Given this list of marker genes C6orf120, MAPK14, ECE2, CIT, UBE2W, RGS6, UBE2F, PAPPA, FAM133B, CAPN3, PDHX (pyruvate dehydrogenase complex component X), B4GALT3, RNFT1, HNRNPF, RXRA, NETO1, ARFGEF1, PGAP1, CCNJ, NCOA1, PKIA, DPY19L3, FOXP2, HLX, PARD6B, AFAP1, USP42, TMTC2, PEDS1-UBE2V1, HIP1, EIF6, USP46, MKNK2, AKIRIN1, AQP11, ADAM19, ATXN10, CD28, N4BP1, MMD, MBNL2 (muscleblind like splicing regulator 2), HAPLN1 (NCBI Gene Id 1404), CREB1, EPB41L1, WSB1, DNAJC13, FAM13A, MEIS2, SLC39A13, C1orf21, PPM1E, EGFR, BMI1, GPAM, PRICKLE2 (NCBI Gene Id 166336), RCAN2, NABP1, RBPMS2, NEO1, CAMTA1, PLEKHH2, PDPK1, IRS1, BAHD1, GATAD2A, DOT1L, SMARCA1, MED13L, FLRT2, QKI, LITAF, STIMATE, PDLIM5, SH2D3C, LPCAT1, HOXA13, CCDC92, JMJD1C, ARHGAP12, ANK1, GLRA2, FAM222A, KCTD4, STX16, PANK1, ITGA5, PPARA, NAA50, LPAR6 (lysophosphatidic acid receptor 6), PLXND1, HOXA10, GREB1L, PDE3A, EPHB2, LSM12, VANGL2, SOWAHA, DNAJC27, SEMA6A, MAPK8IP3, MTMR4 (myotubularin related protein 4), VEGFB, STK39, GLTP, CPEB4, VIP, CCNG1, BRPF3, EVI5, SERTAD2 (NCBI Gene Id 9792), FBXO30, HCN4, TLNRD1, NEUROD6, ACOT11, EEPD1, NFE2L2, BTG2, SLC1A2, BEX3, MSI1, MYT1, SAMD10, ABCB9, MIR1915HG, RMND5A, PRKY, THRB, ABCA1, REPS1, ANK2, UBE2V1 (ubiquitin conjugating enzyme E2 V1), HBEGF, EBF3, LBH, BRSK1, CSRNP1, SV2A, SLCO5A1, PSMA1, NRP2, WDTC1, CACNB2, RNF111, GOSR2, COLGALT2, SOX11, RO60, FOXP4, PTGR3, UBE4A, ATP6V1A, BAG2, LIMK1, KCNA6, GCC2, CASC3, DCP2, SFRP1, SOCS6, MTMR10 (myotubularin related protein 10), NOVA1, RYBP, PAQR9, GABRB3, NR5A2, FOXN3, CBFB, ZDHHC17, FAM184A, RPS6KA5, SCAF11 (NCBI Gene Id 9169), NAA15, ST14, DCUN1D4, ARGLU1, TMCC1, MAP2K4, NEURL4, NCOA5, CSNK1G1, DCX, NCBP3, DUSP5, CBFA2T3, SRGAP2, KMT2A (NCBI Gene Id 79951), PPP4C, WIPF2, WNT3A, CA10, DIRAS1, LYPD3, RUNDC3A (RUN domain containing 3A), GFPT2, PLAG1, EDRF1, SS18L1, YPEL3, TRIM23, PDIA5, NCOA7, TMUB1, GOLM1, ST6GALNAC3, CAB39, GALNT3, DLL4, RIMS3, MTURN (NCBI Gene Id 222166), EPB41, VAV3, RUFY3, LONRF1, DTNA, STIM2, ATP11C, PLAGL2, NHS (NHS actin remodeling regulator), NDUFS4, FRS3, RNF139, ARRDC4 (NCBI Gene Id 91947), ZKSCAN2, MATN3, PPME1, KDM3A, SUCO, RPS6KB1, GNS, FAM193B, CCM2, CTDSP2, HYCC2, ENAH, FLRT3, NRIP1, NKAPD1, CREBRF, UNC5D, GATA2, SYDE1, MANEAL, CDH11, CLCN5, POGLUT1, CD2AP, MICU3, PDE7B, SLC38A4, NEK2 (NIMA related kinase 2), STK40, RPN1, NRBF2, ELL2, SP1, LIFR, UBR5 (ubiquitin protein ligase E3 component n-recognin 5), KCNK2, PGM2L1, LIF, MARCKS, AMMECR1L, CLCN3, PTPN3, PCDH17, SNAP25, SLC35F1, MFSD2A, SH3RF1, PRKX (protein kinase cAMP-dependent X-linked catalytic subunit), PNKD, ATP2B1, CYP39A1, SLITRK1, EDAR, TAB3, TMED5, ZBTB39, PITPNM2, MOB1B, TRAPPC8, EDNRA, HERC2P9, ADAMTS10, HYCC1, EN2, NPEPPS, RETREG3, AK2, GSPT1, AFF4, ARID2, EYA4, GREM1, INSR, SLC6A1, SGPP1, RNF38, SH3BGRL2, NXF1, RGPD5, SEPTIN3, TAPT1, URGCP, PLEKHH1, SATB2, CDK18, SZRD1, TSC1, ADORA2B, AGO2, PPARG, SRSF1, GRB2, EYA1 (EYA transcriptional coactivator and phosphatase 1), ADCY3, ELMO1, MAP2K7, ZFP36L1, CLK1, TMEM9B, CABP1, APPBP2, RNF144A, E2F7, MIER2, POU3F2, NKAIN1, ORC5, RPGRIP1L, ZNF800, CHRD, C1orf52, SYT1, CDIP1, UBE2N, ACVR2A (activin A receptor type 2A), ZNF827, RGS1, TRIL, PDS5B, TGFBR1, SIPA1L3, KBTBD8, SPRY2, EIF2S2, INPP5J, ACVR1, IRF4, UBE2NL, MOSPD3, CADM1, HOXC6, AGRN, RLIM, YWHAB, H3-3B, PTPRT, HOXB3, CPEB3, WEE1, FBXO33, CEMIP, PHB1, CCNK, UNKL, SGMS1 (sphingomyelin synthase 1), OTULIN, CIPC, ISL1, SPTY2D1, ZHX1, CRACDL, PTPN9, ADGRG6, RNGTT, DVL2, GNG12, STARD7, APBA2, NRK, SPATA2, PTGER4, CA12, CNOT7, MIER3, RELN, KPNA3, SEMA6D, NGFR, NREP, PAK6, FZD7, SLC7A11, FBXW7, MBD2, E2F6, TMEM266, FAM78A, SLC39A11, CA7, WASHC4, TMEM25, RAB11FIP1, MEPCE, TLK2, RGL2, MED14, NFASC, ADCY6, CDH5, FOXO1, UBR1, APAF1, NR2F6, FOSB, NRXN1, ZNF385A, PLPPR5, CDH24, CACNA2D3, HMGB3, OTX2, IFFO1, GALNT7 (polypeptide N-acetylgalactosaminyltransferase 7), AGPAT4, VANGL1, ITPKC, ZZZ3, RARA, ELFN2, STAG1, CABLES2, ZFHX4, CAPZA1, CDS1, RUNX1, TBX5, PLK2, CHST1, POM121, CCDC71, ING5, SREK1, PHLPP2, KLHL4, BCORL1, ZCCHC24, CSF1, TMSB10, EHD3, PPP1CC, NXT2, UBE2Q1, ID2, HOXB8, PDGFRA, NAV2, DKK2, H3-5, LZTS3, BCL3, CDC42, ITSN2, RND3, MDFI, HYOU1, EDEM3, ARMC8, RAD54B, NEK6, NPTX2, MAN2A1, NEDD4, here is a description of the gene set: Human Gene Set: ACTGTGA_MIR27A_MIR27B Genes having at least one occurence of the motif ACTGTGA in their 3' untranslated region. The motif represents putative target (that is, seed match) of human mature miRNAs hsa-miR-27a and hsa-miR-27b (v7.1 miRBase). studied in species Homo sapiens